Given this list of marker genes DMGDH, ENPP6, SLC44A1, ALDH7A1, CHDH, BCHE (butyrylcholinesterase), here is a description of the gene set: species: Homo sapiens The chemical reactions and pathways involving choline (2-hydroxyethyltrimethylammonium), an amino alcohol that occurs widely in living organisms as a constituent of certain types of phospholipids and in the neurotransmitter acetylcholine. Human Gene Set: GOBP_CHOLINE_METABOLIC_PROCESS